Given this list of marker genes BUD23, ELN, FIG4, GTF2I, VAC14, FKBP6, COL3A1, ENPP1, XYLT2, YY1AP1, STAT1, ABCC6, RFC2, STX1A, BAZ1B (NCBI Gene Id 9031), EIF4H, DNAJC30, CLIP2, NCF1, TBL2, LIMK1, XYLT1, METTL27, VPS37D, TMEM270, NF1, GTF2IRD2 (GTF2I repeat domain containing 2), GTF2IRD1, here is a description of the gene set: The presence of hypertension related to stenosis of the renal artery. Renovascular hypertension Human Gene Set: HP_RENOVASCULAR_HYPERTENSION studied in species Homo sapiens